Given this list of marker genes Krt10, Cpsf6, Gria3, Hsd17b8, Farsa, Pkd2, Cbr4, Cpsf7, Farsb, Krt1, Pkd1, Grin2b, Nudt21, Rrm1, Rrm2, Grin1, here is a description of the gene set: species: Mus musculus The formation of a protein heterotetramer, a macromolecular structure consisting of four noncovalently associated subunits, of which not all are identical. Mouse Gene Set: GOBP_PROTEIN_HETEROTETRAMERIZATION